Given this list of marker genes SLCO2A1, CEBPD, PTGDS, CCL2, CYP1B1, HLA-DPA1, IL33, VCAM1, CCL14, MGP, SOD2, PLAT, VWF, HLA-DQB1, TSPAN7, NCOA7, POSTN, RAMP3, ZNF385D, ICAM1, HAPLN3, IL1R1, NPC2, TFPI, FBLN2, HLA-DPB1, CD74, ADIRF, C7, SELP, CXCL2, NNMT, HLA-DRA, ARL4A, HLA-DRB1, PRCP, HLA-DRB5, HLA-DQA1, MMRN1, DUSP23, SNCG, HLA-DMA, IER3, ACTN1, ACKR1, SELE, CPE, CLU, NR2F2, LIFR, here is a description of the gene set: Genes upregulated in subsets of cells of a given type within various tumors In this study, an extensive analysis was conducted to define meta-programs (MPs) capturing intra-tumor heterogeneity across a spectrum of tumor types. The approach utilized non-negative matrix factorization (NMF) to analyze each cell type separately within individual tumor samples. This involved the analysis of malignant cells, macrophages, fibroblasts, endothelial cells, epithelial cells, T-cells, and B-cells. NMF was executed with varying parameter values (K=4, 5, 6, 7, 8, 9), thereby generating 39 programs for each cell type per sample. Each NMF program was summarized by the top genes based on NMF coefficients.\nRobust MPs were then delineated for each cell type using a set of stringent criteria, including recurrence within the same tumor, similarity to programs in other tumors, and non-redundancy within a tumor. Subsequently, these robust NMF programs were clustered (per cell type) based on Jaccard similarity, leading to the identification of MPs associated with each cell type.\nTo enhance the quality of the MPs, a refinement steps were undertaken, involving the removal of MPs suspected of reflecting low-quality data (with an overrepresentation of ribosomal proteins or mitochondrial-encoded genes), single-study inclusion, or similarity to miss-annotated cell types. from publication Gavish A, Tyler M, Greenwald AC, Hoefflin R, Simkin D, Tschernichovsky R, Galili Darnell N, Somech E, Barbolin C, Antman T, Kovarsky D, Barrett T, Gonzalez Castro LN, Halder D, Chanoch-Myers R, Laffy J, Mints M, Wider A, Tal R, Spitzer A, Hara T, Raitses-Gurevich M, Stossel C, Golan T, Tirosh A, Suvà ML, Puram SV, Tirosh I (PMID 37258682) Human Gene Set: GAVISH_3CA_METAPROGRAM_ENDOTHELIAL_HEV_1 species: Homo sapiens